Given this list of marker genes Taok3, H2aj, Trem2 (NCBI Gene Id 83433), Rpl11, Snx20, Snf8, Atp5if1, Mycbp2, Rbm3, Mrpl20, Rpl18, Rps15 (ribosomal protein S15), C3, Spag9, Apoe, Mcemp1 (NCBI Gene Id 69189), Wasf2, Grcc10, Eif3m, Rpl31, Spcs1, Stx8, Npm1, Tmem256, Rpl28, Rps2, Stmp1, Cox5b (NCBI Gene Id 12859), Rps17, Scand1, Ndufb6, Dusp11, D8Ertd738e, Snrpd2, Rplp0 (ribosomal protein lateral stalk subunit P0), Macf1, Rplp2, Prdx1 (peroxiredoxin 1), Srrm2, Rpl10a, Ube2f, Atp5pd, Atp6v1f, Mrpl28, Iqgap1, Cir1, Use1, Aurkaip1, Prrc2c, Fam111a, Vcf1 (NCBI Gene Id 28081), Il1b, Rex1bd, Trappc6a, Rpsa, Pgls, Tnfaip8 (tumor necrosis factor, alpha-induced protein 8), Rbm39, Wfdc17, S100a6 (S100 calcium binding protein A6 (calcyclin)), Filip1l, Edf1, Bbln, Itgb1, Acp5, Aprt, Aldoa, Eif3i, Atp5f1c, Cenpx, Rps23, Zfas1 (zinc finger, NFX1-type containing 1, antisense RNA 1), Zfp106, Fau, Atp5f1d (NCBI Gene Id 97661), Fcgr4, Tspo, Dnaja1, Ccl9 (NCBI Gene Id 20308), Ctsd, Rpl8, Nme1, Rel, Pgk1, Ptpn1, Rpl22, Clec4e, Smc1a, Eif3k, Ssu72, Rps27a, Ramp1, Ndufa4, Etfb, Rps16, Luc7l3, Rpl35, Mrpl34, Eif3a, Rpl32, Fkbp2, Cyb5a, Dad1, Aimp1, Lamtor1, Mrps14, Fgfr1op2, Tpi1, Krtcap2, Cox5a, Gmfg, Atp5po, Rps19, Washc2, S100a10, Ctsl, Ciao2a, Nedd8, Rps25, Elob, Cbl, Sod2, Tmem208, Rassf4, Gapdh, Acin1, Cuedc2, Rps7, Dnm2, Mif, Vamp8, Zfp36l1, Pfdn6, Prorsd1, Ifi27, Rps11, Cybb, Fermt3, Mrps24 (NCBI Gene Id 67297), Pafah1b1, Rpl36a, Hint1, Polr1d, Ncbp2as2, Ndufb5, Uqcrq, Rtf1, Naca, Sod1, Uqcr10, Csf2rb, Reep5 (receptor accessory protein 5), Blvrb, Rpl27, Imp3, Sf3b2, Atp2b1, Mien1, Ap2s1, Pfdn5, Rbm25, Rpl21, Smim11, Bet1, Tpr, Eif5b, Creg1, Swi5, Ak2, Rps12, Srp14, Ralbp1, Tmem234, P4hb, Prelid1, Metap2, Atxn7l3b, Rpl17, Rpl7a, Psmb6, Micos10, Cx3cr1, Rps14 (ribosomal protein S14), Ndufs6, Rpl19, Jak1, Cyba, Mrps33, Cd300e, Ifitm1, Cox8a, Kif5b, Psmb3, Rwdd1, S100a11, F10, Ube2b, Cstb, Hacd4, Nfe2l2, Uqcr11, Tax1bp1, Chmp2a, Atp5f1a, Mrpl54, N4bp1, 0610010K14Rik, Emb, Rnasek, Marcks, Usp34, Asnsd1, Slc25a37, Prdx2, Hp, Tgm2, Mrpl52, Rpl18a, Cd52, Nol7, Ndufb10, Psmb1, Fn1, Rpl41, Pkm, Eif3e, Pbx1, Rps13, Sec11c, Dph3 (NCBI Gene Id 75408), Ndufa8, Rp9, Rpl6, H1f4, Lmo4 (LIM domain only 4), Smdt1, Rps3, Lamtor4, Agpat4, Rsrp1, Rps5 (NCBI Gene Id 20103), Clec4d, 2410006H16Rik, Fas, Polr2j, Rps20, Cdv3, Snrpg, Rpl23a, Lamtor2, Rpl13a, Rpl23, Ncf4, Ms4a6d, Lgals1, Pycard, Mrpl23, Tubb5, Rps9, Emg1, Rpl24, Mettl23, Slpi, Supt4a, Rilpl2, Rps10, Eef1b2, Rpl29, H2az1, Ndufa2, H2az2, Rpl10, Micos13, Mrpl14, Apoc2, Taf9, Rpp21, Plek, Atp5pf, S100a8, Tmem14c, Lgals3, Mrpl30, Map1lc3b, Cnpy2, Nme2 (NCBI Gene Id 18103), Ifi30, Rpl15, Atox1, Llph, Jtb, Atp5mc1, Mrpl36, Son, Lsm6, Bcl2a1b, Ndufa5, Ctla2a, Grina, Zbtb7a, Ccdc12, Ncl (nucleolin), Xpa, Hck, Pirb, Rtraf, F13a1, Tnrc6b, Pilra, Rexo1, Syk, Itgb1bp1, Rpl13, Ccl5, Ier3, Tnfaip8l2, Atp5mf, Siva1, Rps8, Ppib, Spata13, Gsn, Rps4x, Ldha, Ly6a, Fcho2, Psmb4, Ndufb7, Susd6, Fth1, Tmem160, S100a9, Rps6, Rpl7, Mrpl42, Pold4, Ifitm2, Rere, Uba52, Esd, Cox7a2, Bcl3, Tbcb, Sec61b (NCBI Gene Id 66212), Rpl12, Chd4, Eif3d, Ssr4, Clta, Tnfaip2, Tmed10, Cox7a2l, Marcksl1, Rpl36al, Id3, Ndufb8, Ndufv3, Nhp2, B230219D22Rik, Rplp1, Rpl27a, Lsm12, Wdr83os, Hcst, Mrpl18, Ndufa13, Trmt112 (tRNA methyltransferase 11-2), Uqcc3, Acap2, Tm2d2, Rps18, S100a13, Txn1, Rrbp1, Dnajc15, Sfr1, Ddt, Park7 (NCBI Gene Id 57320), Eif3c, Atp5mc2, Sp140, Pop5, Cox4i1 (cytochrome c oxidase subunit 4I1), Mpc1, Rpl14, Tomm22, Scaf11, Clec4a2, Uqcrh, Eef1d, Ndufb11, Cox6b1 (cytochrome c oxidase, subunit 6B1), AW112010, Ndufa11, Rps3a1, here is a description of the gene set: from publication Tabula Muris Consortium (PMID 32669714) species: Mus musculus Mouse Gene Set: TABULA_MURIS_SENIS_LUNG_INTERMEDIATE_MONOCYTE_AGEING